Given this list of marker genes LINGO1, RPP25, PPCDC, RN7SL429P, MRPS15P1, RN7SL214P, ADPGK-AS1, NEIL1, ENSG00000252722, PPIAP47, GOLGA6D, RN7SL278P, LINC02259, CLK3, RPL13P4, GOLGA6B, MPI (NCBI Gene Id 4351), ISLR (NCBI Gene Id 3671), SCAMP5, UBE2Q2, ADAMTS7P3 (ADAMTS7 pseudogene 3), KRT8P23, SCAPER, MIR3713, SNUPN, COMMD4P2 (NCBI Gene Id 732265), ADPGK, ARIH1, PPIAP46, LINGO1-AS1, MIR4513, DNM1P33, HMG20A, RN7SL327P, MIR630, RN7SKP217, RN7SL319P, ISL2, INSYN1, MIR4313, TSPAN3, ENSG00000275527, COX5A, COMMD4, ENSG00000259422, RN7SL489P, LOXL1-AS1, C15orf39, REC114, ENSG00000260660, STOML1, ISLR2, CPLX3, ENSG00000212279, ENSG00000260288 (novel transcript), ENSG00000248540, GOLGA6A, DNM1P49, RN7SL510P, CYP11A1, ENSG00000299272, MIR6881, MAN2C1, SIN3A, PML, CYP1A1, SNX33, TBC1D21, ENSG00000259362, MIR6882, COMMD4P1, TYRO3P, GOLGA6FP, CCDC33-AS1, CSPG4, NEO1, NRG4, PEAK1, IMP3, RCN2, GOLGA6C, CD276, RN7SL853P, CYP1A2, UBL7, STRA6, LINGO1-AS2, HIGD2B, DNM1P34, ARID3B, NPTN-IT1, TMEM266, NPM1P42, SCAMP2, NIFKP4, NPTN, NPM1P43, BBS4, FBXO22, DNM1P35, CSPG4P13, ENSG00000259420, LMAN1L, EDC3, PSTPIP1, CCDC33, LINC02255, ETFA, RPL36AP45, GOLGA6EP, INSYN1-AS1, TMEM202-AS1, PHB1P20, FKBP1AP2, ANP32BP1, MIR631, SEMA7A, CIMAP1C, ULK3, HCN4, PTPN9, CSK, LOXL1, UBL7-DT, FAM219B (family with sequence similarity 219 member B), here is a description of the gene set: Human Gene Set: chr15q24 species: Homo sapiens